The following is a description of a gene set: species: Homo sapiens Fragile nails Nails that easily break. Human Gene Set: HP_FRAGILE_NAILS, and this is the list of marker genes: LAMB3, GTF2H5 (NCBI Gene Id 404672), ERCC2, RNF113A, ATP6V0A2 (NCBI Gene Id 7854), ATP2A2, SIN3A, EFNB1, SMARCD2, LMNA, FOSL2, ERCC3, CARS1, CAMK2G, SIN3B, KRT14, GJA1, FTL, GTF2E2, TARS1, AP1B1 (NCBI Gene Id 162), AARS1, DLX3, COL7A1, MSX1, MPLKIP, PRKD1, SLURP1, TRPS1, HRAS, DSP, HEPHL1